The following is a description of a gene set: Mouse Gene Set: chrXC3 species: Mus musculus, and this is the list of marker genes: Gm14813, Igbp1, Gm9043, Zfx, Gm5402, Gm14902, Gm14816, 1700010D01Rik, Gm16394, Mir223, Pcna-ps1, Rpl17-ps8, Gm14828, Mageb18, Maged1, Gm14812, Arx, Gm14830, Mir676, BC061195, Pja1, Zxda, Apoo, Gm39526, Dlg3, Gm6987, Gm9009, Eda, Gm24718, Klhl15, Heph, Gm24123, Gm6985, Gm24595, Arhgef9, Gm9062, Gm14802, Gm5941, Gm15165, 1700003E24Rik, Las1l, Pdzd11, Awat2, Gm14933, Mir223hg, Arr3, Gm9051, Gpr165, Gm6982, Gm7061, Gm14826 (NCBI Gene Id 670263), Pdk3, Gm5401, Eda2r, Ophn1, P2ry4, Spin4, Gdpd2, Gm9059, Awat1, Gm3712, Gm14806, Gm14925, Otud6a, Gm14827, Nalf2, Gm5760, Yipf6, Vsig4, Dgat2l6, Stard8, Zxdb, Gm23454, Gm27510, Gm371 (NCBI Gene Id 236914), Fam90a1b, Gm26000, Gm15164, Pgr15l, Gm6175, Hsf3 (heat shock transcription factor 3), Eif2s3x (eukaryotic translation initiation factor 2, subunit 3, structural gene X-linked), Gm14935, Asb12, Gm14808, Zc3h12b, AU015836, Gm23557, Mir7673, Zc4h2, Rpl13-ps5, Kif4, Gm14800, Ar (androgen receptor), Gm14815, Msn, Gm14829, Gm9060, Pcyt1b, Amer1, Gm9005, Gm14780 (NCBI Gene Id 100416302), Gspt2, Gm9003, Gm5400, Pola1, Efnb1, Gm14866, Pfn5, Gm14825, Gm14803, Gm24577, Gm6092